Given this list of marker genes Ccnl2, Ccnq, Cdkn1c, Cdkn2b, Inca1, Ccnjl, Cdkn2c, Ccnt1 (cyclin T1), Ccnh, Ccno, Ccnk, Ccnb2, Tex24, Ccnj, Ccnf, Ccnb1, Ccnb1-ps, Ccna2, Cnppd1, Hexim1, Hexim2, Ccne2, Ccny, Casp3, Ccnc, Ccnb3, Cdkn2a, Cdk5r2, Cks1brt, Cdkn1a, Cks2, Cdk5r1, Ccne1, Ccnd2, Cdkn1b, Ccni, Ccnl1, Ankrd42, Cks1b, Ccnt2, Mnat1, Ccng1, Ccna1, Ccng2, Ccnd1, Ccnd3, Cdkn2d, Kat2b, here is a description of the gene set: Modulates the activity of a cyclin-dependent protein serine/threonine kinase, enzymes of the protein kinase family that are regulated through association with cyclins and other proteins. Mouse Gene Set: GOMF_CYCLIN_DEPENDENT_PROTEIN_SERINE_THREONINE_KINASE_REGULATOR_ACTIVITY species: Mus musculus